Given this list of marker genes Wiz, Katnal2, Smim29, Zscan20, Ier2, Cd276, Tfcp2, Kmo, here is a description of the gene set: Genes predicted to be targets of miRBase v22 microRNA mmu_miR_12191_5p in miRDB v6.0 with MirTarget v4 prediction scores > 80 (high confidence targets). Mouse Gene Set: MIR_12191_5P studied in species Mus musculus from publication Chen Y, Wang X (PMID 31504780)